The following is a description of a gene set: Mouse Gene Set: GOBP_REGULATION_OF_FATTY_ACID_TRANSPORT species: Mus musculus Any process that modulates the frequency, rate or extent of fatty acid transport., and this is the list of marker genes: Mapk9, Oxt, Acsl1, Thbs1, Erfe, Sstr4, P2rx7, Cyp4a31, Edn1, Hrh2, Hrh3, Avpr1b (arginine vasopressin receptor 1B), Akt2, Cyp4a32, Il1b, Mif, Ntsr1 (neurotensin receptor 1), Fabp3, Syk (NCBI Gene Id 20963), Tnfrsf11a, Pla2r1, Tnfsf11, Pla2g4a, Fis1, Irs2, Eprs1 (glutamyl-prolyl-tRNA synthetase 1), Acacb, Acsl5, P2ry2, Ptges, Agtr2, Cyp4a10, Acsl6, Pla2g10, Pla2g6, Repin1, Pla2g3, Acsl4, Map2k6, Il1a, Akt1, Atp5pf